The following is a description of a gene set: Human Gene Set: GSE43863_NAIVE_VS_LY6C_INT_CXCR5POS_CD4_EFF_TCELL_D6_LCMV_DN species: Homo sapiens Genes down-regulated in CD4 SMARTA T cells: naïve versus Ly6c+ CXCR5+ effector during acute infection of LCMV. from publication Hale JS, Youngblood B, Latner DR, Mohammed AU, Ye L, Akondy RS, Wu T, Iyer SS, Ahmed R (PMID 23583644) CD4 T follicular helper (Tfh) cells provide the required signals to B cells for germinal center reactions that are necessary for longlived antibody responses. However, it remains unclear whether there are CD4+ memory T cells committed to the Tfh lineage after antigen clearance. Using adoptive transfer of antigen-specific memory CD4+ subpopulations (based on CXCR5 and Ly6c expression)in the LCMV infection model, we found that there are distinct memory CD4+ T cell populations with commitment to the Tfh and Th1 lineages. Our conclusions are based on gene expression profiles, epigenetic studies and phenotypic and functional analysis. The gene expression profiles of virus-specific CD4 T cell subets at effector and memory stages is presented here., and this is the list of marker genes: MT1M, CLDN9, OR2A4, NOCT (nocturnin), POM121L10P, SOCS2, TLN2, SH2D6 (SH2 domain containing 6), MIR9-1HG, ZNF687, TNFSF11, CUL9 (NCBI Gene Id 23113), PDE6A, WFDC6, BCL7A, MPIG6B, SDR9C7, MBD3L1, EPHA1-AS1, NLRP6, ADH1A, LINC02043, SELE, NPPA, LYRM4, C2orf92, HYAL4, LINC02431, IL20, VCAM1, UST, CACFD1, KIAA0319, LAMA3, PADI3, SPCS2, SLC22A6, CRYBG2, CNN1, SPINK2, HIVEP3, ARK2C, C1orf94, MYBPC3 (myosin binding protein C3), ZBTB12, NOP9, ANAPC15, PAMR1, CATSPERE, ITPRID1, THBS4, GCM1, SCUBE1, TRAV12-2, UQCC4, CYTL1, C3orf36, SLC5A4, LINC02532, GUCY2D, BRAP, BNIPL, NOC3L, ZFP2, ADCY5, CABCOCO1, SCGB1D1 (NCBI Gene Id 86801), LINC01104, TMEM11, C1orf87, SOCS2-AS1, DDC-AS1, DPPA5P4, EIF4EBP1, CD3D, INHBB, HLCS, PPP1R13B, SLC25A48, MTHFSD, BIRC3, ANKRD13C-DT, ST8SIA2, LHFPL1, GAL3ST1, GID8, LGI3 (NCBI Gene Id 203190), GRIPAP1, DNAAF11, DNAH10, SPX, TTC4 (NCBI Gene Id 7268), HOXD11, FOLR2, FRMD5, TRIM72, CEBPB, LINC-PINT, ABCG8, NTHL1, VASH1, KCNA2 (potassium voltage-gated channel subfamily A member 2), SV2B, MATN4, ANGEL1, BMPR1B, HMCN2, GHRL, DNPH1, TP53AIP1, STOML1, DNAJC25, ZPR1P1, BPIFC, PPEF1, RAB33A, CFHR4, AHI1, ZNF419, LPAR5, TECTB, CXCL1, LINC00305, ARSD, VPS11, TAMALIN, TGM1, PGLYRP2, AKNA, ANXA13, MT2A, RIT2, PLPP7, DTX1, CD300LG, ABCA17P, DBH-AS1, NUPR1, NDRG3, TAS2R13, FBXO36, LRRC28, PXMP2, LRRC8C-DT, GSDMC, GCKR, ZNF557, WDR93 (NCBI Gene Id 56964), PPM1L, EIF6, PLBD1, FAM216B (NCBI Gene Id 144809), MFF-DT, LINC01095, TEKT1, SOX21, OTUD7A, PDZRN3, LINC01281, GS1-279B7.1, PER2, TEF, TREX2, SPATA3, RAB31, LOXL3, OPA3, AMACR, SAMD10, ZHX3, XAB2, LINC02860, FOXI1, STK31, ITGB2, ADRB3, C12orf42, YIPF2, CCK, PTH1R, DPEP2NB, GCHFR, TUBGCP6, MRPL14, LINC02026, RNASEH1-DT (NCBI Gene Id 100509412), AA06, ZNF766, ENHO (energy homeostasis associated), OTOS, IFNLR1, CRYBB3, TMEM176A, LINC00511